The following is a description of a gene set: studied in species Mus musculus The chemical reactions and pathways involving proteoglycans, any glycoprotein in which the carbohydrate units are glycosaminoglycans. Mouse Gene Set: GOBP_PROTEOGLYCAN_METABOLIC_PROCESS, and this is the list of marker genes: Hexa, Pxylp1, Hs3st6, Chst14, Hgsnat, Chpf2, Cytl1 (cytokine-like 1), Dse, Chst11, Hs3st5, Gusb, Ctsl, Bmpr1b, B4galnt4, B3gnt7, Ppard, Vangl2, Hs3st3a1, Sgsh, Dsel, Slc2a10, Slc10a7, Chst1, Hs3st2, Ugdh, Angpt1, Chst13, Naglu, Ednra, Arsb, B4galt7, Ctnnb1, Btk, Adamts7, Chpf, Chst12, Xylt2, Tm9sf2, B3gat3, B3gat1, B3galt6, Ednrb, Ext1, Chst9, Igf1, Col2a1, Chst5, Man1c1, Chsy1, Hs3st3b1, Hs6st3, Hs3st1, Ndst3, Galnt3, Csgalnact2, Fam20b, Gns, Hs6st2, Acan, Xylt1, Hexb, Csgalnact1, Galns, Chsy3, Chst8, Mustn1, Ust, Hyal4, Ndst2, Slc35b2, Tcf7l2, Chst7, Ndst4, Ihh, Lipc, Hyal1, Cant1, Idua, B4galnt3, Col11a1, Sulf1, B3gat2, Ext2, Hs2st1, Bmpr2, Gpc1, Sulf2, Bmp2, Ids, Foxl1, Chst10, Glce, Ndst1, Slc35d1, Bpnt2, Chst3, Slc35d2, Hs6st1, Hs3st4, Hpse, Glb1, Extl1, Edn1, Adamts12, B4galt4 (NCBI Gene Id 66823), Extl3